The following is a description of a gene set: Inflammation of blood vessel. studied in species Homo sapiens Human Gene Set: HP_VASCULITIS Vasculitis, and this is the list of marker genes: IRF2BP2, CD244, IFNGR1, SCN11A, DOCK8, IL12A, HLA-B, SYK, TBK1 (TANK binding kinase 1), HLA-DRB1, SCN10A, MEFV, NOD2, NLRP3, ADA2, C1QB, PSTPIP1, TLR4, NFKBIL1, HLA-DPA1, ARPC1B, OTULIN, DNASE1L3, KLRC4, HCK, PGM3, IL10, CTLA4, CD19, FAS, IL12A-AS1, TNFRSF1A (NCBI Gene Id 8077), ICOS, C4A (NCBI Gene Id 720), CIITA, PNP, IL12B, STAT4, PTPN6, UBAC2, FASLG, LYN, ACP5, MS4A1, IL12RB1, MVK, WIPF1, CASP10, WAS, XIAP, PTPN22, NFKB1, CCR1, ERAP1, IFIH1, TNFRSF13B, P4HA2, CR2, TNFRSF13C, POLR3F, SCN9A, PRTN3, HLA-DPB1, SLC22A4, CFI, TNFSF12, NFKB2, CD81 (CD81 molecule), MLX, SH2D1A, MYD88 (MYD88 innate immune signal transduction adaptor), TREX1, IL23R